Given this list of marker genes NCF1, FKBP6, ITGA6, BUD23 (NCBI Gene Id 84118), DNAJC30, TINF2, FLNA, HNRNPH1, RIN2, SALL1, RFC2, NHP2, NSD1, PARN, LRIG2, ELN, BNC2, TP63, ZMYM2, MMP1, FERMT1, NOP10, VPS37D, PKP1, FLT4, GTF2IRD1, DACT1, GTF2I, TMEM270, MED25 (NCBI Gene Id 81857), EIF4H, LAMA3, MAP3K7, GTF2IRD2, SRCAP, USB1, MKKS, TBX1, RTEL1, MID1, COL7A1, STX1A, TERC, IGF2, SPRED1, TERT, LAMB3, CLIP2, APC2, LAMC2, CHRM3, WRAP53, CTC1, NPM1, BAZ1B, TYMS, ITGB4, TBL2, DKC1 (dyskerin pseudouridine synthase 1), PLEC, PTPRF, LIMK1, HPSE2, METTL27, MLXIPL, SIN3A, POLA1, CDC45, here is a description of the gene set: Obstruction of the flow of urine through the urethra. Urethral obstruction Human Gene Set: HP_URETHRAL_OBSTRUCTION studied in species Homo sapiens